The following is a description of a gene set: studied in species Homo sapiens Any process that modulates the frequency, rate or extent of intrinsic apoptotic signaling pathway by p53 class mediator. Human Gene Set: GOBP_REGULATION_OF_INTRINSIC_APOPTOTIC_SIGNALING_PATHWAY_BY_P53_CLASS_MEDIATOR, and this is the list of marker genes: ARMC10, RPL26, TRIAP1, ATAD5, ZNF385A, BDKRB2, SIRT1, USP15, RRN3, TAF9, MUC1, PRKN, KDM1A, TAF9B, TP53, EIF5A, TP73, MYC, PTTG1IP, BCL2, RRM2B, UBB, ING2, BCL2L12, MIR21, RPS7, ELL3, MIR186, MDM2, CD74, MSX1, MIF, TIFAB, MARCHF7, CD44, HNRNPK, TP53BP1